Given this list of marker genes FLT3, here is a description of the gene set: studied in species Homo sapiens Reactome Pathway: ponatinib-resistant FLT3 mutants Ponatinib is a first generation tyrosine kinase inhibitor with activity against a broad range of receptor tyrosine kinases, including FLT3 (reviewed Pemmeraju et al, 2014; Kazi and Roonstrand, 2019). This pathway describes FLT3 mutants that are resistant to inhibition by ponatinib. part of: Drug resistance of FLT3 mutants